The following is a description of a gene set: RNA Polymerase II promoter escape occurs after the first phosphodiester bond has been created. species: Homo sapiens Reactome Pathway: RNA Polymerase II Promoter Escape part of: RNA Polymerase II Transcription Initiation And Promoter Clearance, and this is the list of marker genes: POLR2C, GTF2H2, TAF15, POLR2E, TAF5, TAF4B, TAF6, ERCC3, TAF8, POLR2D, TAF3, GTF2E2, POLR2L, TAF12, TAF7, MNAT1, POLR2A, POLR2J, CCNH, TAF13, TAF7L, GTF2H1, GTF2F2, GTF2E1 (NCBI Gene Id 2960), TAF9B, GTF2A1, GTF2F1, TBP, TAF10, POLR2K, TAF1, CDK7 (cyclin dependent kinase 7), TAF1L, POLR2H, POLR2I (RNA polymerase II subunit I), GTF2H3, TAF9, GTF2H4, ERCC2, GTF2A2, POLR2F, TAF2, GTF2H5, TAF4, POLR2G, POLR2B, TAF11, GTF2B